The following is a description of a gene set: Mouse Gene Set: GOBP_REGULATION_OF_NON_CANONICAL_WNT_SIGNALING_PATHWAY Any process that modulates the frequency, rate or extent of non-canonical Wnt signaling pathway. studied in species Mus musculus, and this is the list of marker genes: Csnk1d, Rspo1, Ankrd6, Mir154 (microRNA 154), Dab2, Plekha4, Sfrp4, Nkd1, Tiam1, Csnk1e, Mllt3 (myeloid/lymphoid or mixed-lineage leukemia; translocated to, 3), Daam2, Abl1, Gpc3, Rnf213, Wnt5a, Lrp6, Dact1, Sfrp5, Mks1, Spef1, Abl2, Wnt5b, Ift80, Lbx2, Sfrp1, Nphp3, Rspo3, Znrf3